Given this list of marker genes KCNH2, DDC, SLC6A17, PGAM2, KCNJ6, RGS4 (NCBI Gene Id 5999), RIMKLA (ribosomal modification protein rimK like family member A), LINC02955, ETS2-AS1, SPHKAP, QPCT, SLC18A1, ASCL2, PHGR1, HES6, SEC11C, NR0B2, NREP-AS1, POTEI, CHGA, PCSK1, SYT13, TMPRSS6, AMIGO2, LMX1B (LIM homeobox transcription factor 1 beta), LINC00261, RAB26, COL22A1 (collagen type XXII alpha 1 chain), KSR2, NPSR1-AS1, CACNA1A, SLC16A12, RASD1, VGF, HEPACAM2, OR51E1, PTGFR, DLL3, KLK12, RPRM, GRP, SFRP4, MBOAT4, INSM1, CHDH, GFRA3, ACSL1, RFX6, GHRL, TMEM132D, CHRD, SSTR5-AS1, ABCC8, GPX2, CA8 (NCBI Gene Id 767), PDCD6IPP2, BTBD17, NKX2-2, MMP26, TRPC7-AS1, PKD2L1, TMEM198, ASCL1, NDUFB2-AS1, SLC38A11, CPE, ENSG00000253726, SV2B, NPTX1, GHRLOS, FIBCD1, HTR2C, KCNH6, CALCA, OPRD1, KCNIP3, NEUROD1, TTR, KCND3, GKN2, POTEJ, TPH1, SMIM32, TFF1, MAOB, RHBDL1, VWA5B2, NOL4, A1CF, NPC1L1, GRIK1, here is a description of the gene set: studied in species Homo sapiens from publication Cao J, O'Day DR, Pliner HA, Kingsley PD, Deng M, Daza RM, Zager MA, Aldinger KA, Blecher-Gonen R, Zhang F, Spielmann M, Palis J, Doherty D, Steemers FJ, Glass IA, Trapnell C, Shendure J (PMID 33184181) Human Gene Set: DESCARTES_FETAL_LUNG_NEUROENDOCRINE_CELLS The gene expression program underlying the specification of human cell types is of fundamental interest. The study authors generated human cell atlases of gene expression and chromatin accessibility in fetal tissues. For gene expression, the study authors applied three-level combinatorial indexing to >110 samples representing 15 organs, ultimately profiling ~4 million single cells. The study authors leveraged the literature and other atlases to identify and annotate hundreds of cell types and subtypes, both within and across tissues. Our analyses focused on organ-specific specializations of broadly distributed cell types (such as blood, endothelial, and epithelial), sites of fetal erythropoiesis (which notably included the adrenal gland), and integration with mouse developmental atlases (such as conserved specification of blood cells). These data represent a rich resource for the exploration of in vivo human gene expression in diverse tissues and cell types. Marker genes curated from the annotated cluster as represented in the Descartes Human Gene Expression During Development database.